Given this list of marker genes ASB8, BPIFB6, LINC01550, MCUB, ATXN3L, BCL2L14, C3orf70, CYP4Z1, DLX1, CETN2, FUNDC1, BCS1L, FAM50A, ADAMDEC1 (ADAM like decysin 1), COBL, TRMT13, CCNY, BPI, CHST12, ASB12, CNPY1, DOCK2, ETV6, ENTPD3, FOXRED2, TMA7, ATP13A5, RHNO1, BLCAP, FAM83C, CLDN2 (NCBI Gene Id 9075), ADCY9, EFCAB10, CCDC88C, FBXL14, CYTIP, SCN8A, DNAJB14, DNASE1L2, ARPIN, FGF13, CD40LG, ZNF736, CTAG2, CTSC, CYTH2, ZNG1A, FOSL2-AS1, AMER2, CYP2J2, FAIM, EIF5A2, OGFOD3, BCL11A, CSPG5, DNAJC28, CHPF, ALX4, DHX58, CLU (clusterin), CYFIP1, CCDC15, TMEM8B, BID, CST11, C2orf15, CHRNA4, CACNG7, LINC01588, CCDC28B, C12orf60, MUCL3, CCDC115, TEX38, ARHGEF5, EXOC2, CHRM5, FOS, ASF1A, TBATA, BBS1, NDNF (NCBI Gene Id 79625), CES1 (NCBI Gene Id 1067), CSH1, DLD, DACT1, ALDH1L2 (NCBI Gene Id 160428), CGNL1, MFSD12, CALCA, CXCL2, MVB12A, PCDH17, CYBA, ATRN, ARHGAP5, NOCT, C8orf17, CYP4F29P, ADAMTSL1, CDHR5, FAM47A, DOHH, FAAP100, LAMP5, GPAT4, DUSP14, ALDH16A1, ARHGEF19, EPHX3, CPNE3, SLC25A3P1, CBY3, MVB12B, CDH15, AEBP2, FAP, ADAMTSL3, ATOH7, CFAP47, CPNE9, EVL, AFAP1, PAGR1, FBXL16, CD8B, NR2F1-AS1, FKRP, FPGS, ALKBH7, CEACAM19, LINC03040, TBC1D32, C9orf85, COA3, ALOX12, DAD1, APOL6, INHBE, LINC01949, ADH7, FHL1, CHRNB2, EIF3K, ADAMTS5, ZBTB7C-AS2, CSNK2B, C3orf85, ACVR2A, FST, AAMP, CLTCL1, EVX1, DPYS (dihydropyrimidinase), CCDC152, CHRNA1, EXOC7, SCP2D1, FAM87A, B3GAT1, ZGRF1, BBOX1, FTH1, BDNF, CHMP1A, RMDN3, DDX11L2, FLYWCH2 (NCBI Gene Id 114984), AGK, COMMD5, CABP2, DMTN, BOLA3, BCOR, BCDIN3D, CYLD, CEP68, SIGLECL1 (SIGLEC family like 1), SPMIP10, CPLX2, CAMK1D, LINC02880, ETS1, LINC02210, LINC00951, ARHGAP35, ARL4A, FAM86C1P, ART4, ENTPD2, SUCO, FOXL1, CD7, DUS1L, FBXW9, CHRNB1, here is a description of the gene set: Human Gene Set: GSE15659_CD45RA_NEG_CD4_TCELL_VS_NONSUPPRESSIVE_TCELL_UP from publication Miyara M, Yoshioka Y, Kitoh A, Shima T, Wing K, Niwa A, Parizot C, Taflin C, Heike T, Valeyre D, Mathian A, Nakahata T, Yamaguchi T, Nomura T, Ono M, Amoura Z, Gorochov G, Sakaguchi S (PMID 19464196) Genes up-regulated in comparison of PTPRC- CD4 T cells versus non-suppressive T cells. Gene expression profiles of subsets of CD4+ T cells according to their expression of FoxP3 and CD45RA were compared. FoxP3 is a key transcription factor for the development and function of natural CD4+ regulatory T cells (Tregs). Here we show that human FoxP3+CD4+ T cells are composed of three phenotypically and functionally distinct subpopulations: CD45RA+FoxP3low resting Tregs (rTregs) and CD45RA-FoxP3high activated Tregs (aTregs), both of which are suppressive in vitro, and cytokine-secreting CD45RA-FoxP3low non-suppressive T cells. The proportion of the three subpopulations characteristically altered in cord blood, aged individuals, and patients with immunological diseases. Terminally differentiated aTregs rapidly die while rTregs proliferate and convert into aTregs in vitro and in vivo as shown by the transfer of rTregs into NOD-scid-common gamma-chain-knockout mice and by TCR sequence-based T cell clonotype tracing in peripheral blood of normal individuals. Taken together, the dissection of FoxP3+ cells into subsets enables one to analyze Treg differentiation dynamics and interactions in normal and disease states, and to control immune responses through manipulating particular FoxP3+ subpopulations. species: Homo sapiens